The following is a description of a gene set: studied in species Homo sapiens Human Gene Set: HP_PROTRACTED_DIARRHEA Protracted diarrhea, and this is the list of marker genes: CIITA, CD3D, SDHD, ATRX, RFXAP, RFXANK, CD247, CD3E, RAG2, LCK, MYO5B, RFX5, RAG1